The following is a description of a gene set: studied in species Homo sapiens from publication Chen Y, Wang X (PMID 31504780) Human Gene Set: MIR4267 Genes predicted to be targets of miRBase v22 microRNA hsa-miR-4267 in miRDB v6.0 with MirTarget v4 prediction scores > 80 (high confidence targets)., and this is the list of marker genes: VAMP1, ZNF497, TSC22D1, KLF12, SHISA6, PTPRO, DGKQ, PARP8, MAG, GLS, PIN4, DUSP10, WIPI2, VPS53, PNP, TBC1D16, TRUB2, ABCF2, SAMD12, UCK2, DUSP6, SNPH (syntaphilin), TRAF3, RNF169, HOOK3, JAKMIP3, N4BP2, SLC1A7 (NCBI Gene Id 94490), GLE1, RAB15, PA2G4, NFASC, STK4, SUV39H1, GLRX, FOS, BTG2, FAM53B, KIF13B, POGZ, CSPG4, NCBP2, LRRK1, DACT2, SPRY3, CCDC178, POLR2F, HABP4, ZCCHC17, TCF19, COMMD3, SLC12A5, IHH, ERBB3, TENM4, FCHSD1 (NCBI Gene Id 89848), REXO4, CACNG2, PRKX, TYSND1, YWHAH-AS1, LZTS1, SLC12A3, NCK1, WEE2 (NCBI Gene Id 494551), NFIA, ACSL5, CFLAR, SLC2A10, SMCR8, CWC27, ABHD12, SKA3, MAP7D3, MPI, NKX2-5, SMPD1, KCNE4, SMG8, METTL1, FAM53A, TAB3, LMOD1, BMAL2, CCDC33, CPPED1, COPS2, FAM53C, GCC2, SLC6A17 (NCBI Gene Id 388662), BMPR2, C5orf24, SPPL2A, ZBTB47, ABCF1, CNTN2, MBD6, ANKRD42, SLC22A13, TRPV3, ZNF609, DNAJA4, DIS3, GPRASP2, ADAMTSL1, ALPK3, TRDN, VPS37C, LASP1, DNAJB5, PHF13, SLC1A4, RXFP1, PLEKHM1, SMG7, CD44, MOCS1, ITPRIP, TBC1D2B, PYDC1 (pyrin domain containing 1), SOX11, FOXD4L3, DCAF7, SESN1, TOMM34, ABCA13, BCKDHB, ZNF782 (zinc finger protein 782), CDK5R1, SZRD1, MECP2, ALDH18A1, COG8, STRIP2, RGS16, CRLS1, MSL3, LIMK1, CFAP44, CALHM1, VAPB (NCBI Gene Id 9217), ZC3H12B, KATNIP, PHYHIP, POMGNT1, TNS3, KDM2A, ARMH3, CTTNBP2NL, CCDC186, PHAF1, PPP1R9B, LENG8, DOK5, MED22, COL6A6, RREB1, FAM168A, L3MBTL2, CYP4A22, MINDY2, GDI2, BMP4, CNDP2, PCSK6, DOCK9, CECR2 (NCBI Gene Id 27443), HDAC4, MAST3 (microtubule associated serine/threonine kinase 3), EI24, ARK2C, NANOS1, SEMA6A, SLC39A10, RAB11FIP3, GARRE1 (granule associated Rac and RHOG effector 1), TWIST1, ZNF653, ZNF423, SORT1, VSTM2A, SCAMP5, ZMYND11, UBE2D3, SANBR, PITPNM3, BSDC1, TK2, KCND1, LGR4, CSF1, MBNL1, GNPNAT1, ATP1B3, ZFAND3, EPPIN, HSF5, ZNF623, MSR1, CAPN6, PREX1, SFMBT1, CYLD, TEF, MTFR1L, HUNK, FOXD4L6, RANBP10, AOC3, EFR3B, FOSL1, MAP4K5, CHST3, WFDC11, LDLRAD2, BRD8, CALHM5, SMARCC1, CARHSP1, AGT, TMEM86A, LRRC31, CISH, BCLAF1, SEC24C, FBXO40, HIVEP3, PDF